The following is a description of a gene set: species: Homo sapiens Genes having at least one occurrence of the highly conserved motif M138 MYAATNNNNNNNGGC in the regions spanning 4 kb centered on their transcription starting sites. The motif does not match any known transcription factor binding site. Human Gene Set: MYAATNNNNNNNGGC_UNKNOWN from publication Xie X, Lu J, Kulbokas EJ, Golub TR, Mootha V, Lindblad-Toh K, Lander ES, Kellis M (PMID 15735639) Comprehensive identification of all functional elements encoded in the human genome is a fundamental need in biomedical research. Here, we present a comparative analysis of the human, mouse, rat and dog genomes to create a systematic catalogue of common regulatory motifs in promoters and 3' untranslated regions (3' UTRs). The promoter analysis yields 174 candidate motifs, including most previously known transcription-factor binding sites and 105 new motifs. The 3'-UTR analysis yields 106 motifs likely to be involved in post-transcriptional regulation. Nearly one-half are associated with microRNAs (miRNAs), leading to the discovery of many new miRNA genes and their likely target genes. Our results suggest that previous estimates of the number of human miRNA genes were low, and that miRNAs regulate at least 20% of human genes. The overall results provide a systematic view of gene regulation in the human, which will be refined as additional mammalian genomes become available., and this is the list of marker genes: BCAS3, MORN4, ACAA2, RGS8, ETV5, WDR62, PTK7, KRT9, TSSK2, JAG1, MEX3D, DMD, DCTN2, OARD1, ZNF503, ZNF277, PAQR6, NKX2-1, HOXC11, SOST, USP15, TLE1, RPS6KA5, TMSB10, EPB41L5, PPP2R5D, FKBP5, PCDHGA11, RXRG, POU3F3, NRXN3, DOCK4, BDNF, C6orf62, CSRNP2 (cysteine and serine rich nuclear protein 2), NECTIN1, MAF, PDZD8, AGO1, KCNIP4, LIN28A, CDC20, TNPO2, G3BP2, ANP32A, SEPTIN4, TULP3, DPYSL2, CXCL14, FKBP2, TYK2, BORCS6, GPX1 (NCBI Gene Id 2876), OSBP, NDST2, DAB1, DLX1, LAMA1, PRDM10, KCNA6, ARHGAP44, TLE4, SOX5, HOXD4, LBX1, TUBB2B, RTL9, GTF3C2, CENPF, LUC7L2, PAPOLG, FLI1, AMD1, FAM204A, WASL, ASCL2, CDK17, SLC26A9, FBXL20, THAP8, ARHGEF12, PCYT1B, PANK2, RNF38, SKIDA1, SALL1, NSD1, PRKACA, SYNE2, ZMYND8, SQLE, NFKB2, SEL1L, RABAC1, ARHGAP36, SWAP70, VSX1, SYT4, TMEM132E-DT, PAX6, BBOX1, PLA2G6, XBP1, GABRA6, NFYA, SIX5, NUTF2, BCL2L1, MIS12, FGF3, SRSF6, RBBP6